The following is a description of a gene set: Reactome Pathway: IRAK4 deficiency (TLR2/4) studied in species Homo sapiens part of: Diseases associated with the TLR signaling cascade Interleukin-1 receptor-associated kinase 4 (IRAK4) is a serine/threonine kinase, that mediates activation of transcriptional factors such as NFkB and AP1 downstream of IL-1 receptors and all toll like receptors (TLR) except for TLR3 (Suzuki N et al. 2002). IRAK4 is recruited to the TLR receptor complex through a homophilic interaction of the death domains of IRAK4 and adaptor myeloid differentiation factor 88 protein (MyD88) (Motshwene PG et al. 2009; Lin SC et al. 2010). Studies have identified patients with an autosomal recessive (AR) form of IRAK4 deficiency, a health condition with clinical manifestation in infancy or early childhood, that predisposes affected patients to recurrent pyogenic bacterial infection (e.g., Streptococcus pneumoniae and Staphylococcus aureus) (Picard C et al. 2003; Ku CL et al. 2007; Picard C et al. 2010; Picard C et al. 2011). Leukocytes derived from IRAK4-deficient patients display a lack of production of inflammatory cytokines such as TNF alpha, IL-6 and IL-1 beta by whole blood or a lack of CD62 ligand (CD62L) shedding from granulocytes following activation with the most TLR agonists including those of TLR1/2 (Pam3CSK4), TLR2/6 (Pam2CSK4) and TLR4 (LPS) (Picard C et al. 2003; McDonald DR et al. 2006; Ku CL et al. 2007). However, LPS-induced TLR4-mediated production of some cytokines (IL8 and MIP-1beta) was reduced but not abolished (Ku CL et al. 2007). LPS-stimulated induction of type I IFN via MyD88-IRAK4 independent signaling axis was normal or weakly affected suggesting that TLR4 could induce some responses in IRAK4 deficient patients(Yang K et al. 2005).<p>Patients with AR IRAK4 deficiency were found to bear homozygous or compound heterozygous mutations in the IRAK4 gene (Picard C et al. 2003; Ku CL et al. 2007; McDonald DR et al. 2006). Here we describe selected mutations, that have been functionally characterized. Cell-based assay as well as in vitro protein-interaction analyses with IRAK4 variants showed that the loss-of-function of defective IRAK4 is caused by either loss of protein production (reported for IRAK4 Q293* and E402*) or an impaired interaction with MyD88 as shown for missense mutation IRAK4 R12C (Ku CL et al. 2007; Yamamoto T et al. The module does not include defective TLR7, TLR8 and TLR9 signaling events, which are associated mostly with viral infections, although studies using patient-derived blood cells showed abolished cytokine production by peripheral blood mononuclear cells (PBMCs) and lack of CD62 ligand (CD62L) shedding from granulocytes in response to TLR7-9 agonists (McDonald DR et al. 2006; von Bernuth H et al. 2006; Ku CL et al. 2007). In addition to the TLR-NFkappaB signaling axis, endosomic TLR7-9 activates IFN-alpha/beta and IFN-gamma responses and these are also impaired in IRAK4-deficient PBMC (Yang K et al. 2005). Nevertheless, IFN-alpha/beta and -gamma production in IRAK-4-deficient blood cells in response to 9 of 11 viruses was normal or weakly affected, suggesting that IRAK-4-deficient patients may control viral infections by TLR7-9-independent production of IFNs such as IRAK4-independent antiviral RIGI and MDA5 pathways (Yang K et al. 2005). So it is not yet possible to annotate a definitive molecular pathway between IRAK-4 deficiency and changes in TLR7-9 signaling., and this is the list of marker genes: LY96, MYD88, FGA, S100A1, TLR6, IRAK4, mip, FGG, S100A8, TLR4, HMGB1, TLR2, FGB, porB, TLR1, CD36, S100A9, BTK, TIRAP, CD14